Given this list of marker genes NAMPT, ZFHX3, MYBBP1A, LGR4, KDM8, NOCT, PASD1 (PAS domain containing repressor 1), RORC, PPARGC1A, RELB, TOP1, DRD2, ATF4, SIRT6, OGT, CRY1, MYCBP2, ZPBP2, PER1, ID2, KDM2A, HDAC1, MAGED1, PER3, HUWE1, KDM5A, RBM4B, PER2, RBM4, HDAC2 (NCBI Gene Id 3066), USP2, PRMT5 (NCBI Gene Id 415048), CARTPT, BHLHE41, MTA1, SIRT1, RORA, CAVIN3, CRY2, PPP1CA, CIART (circadian associated repressor of transcription), NR1D1, HNRNPU, RAI1, AHR, MC3R, KMT2A, EGR1, CSNK1D, CLOCK, NPAS2 (NCBI Gene Id 84195), BHLHE40, BMAL2, NCOA2, GFPT1, NGFR, NUDT12, HDAC3, CSNK1E, BMAL1, PPP1CB, DRD3, NRIP1, PPARA, PPP1CC (protein phosphatase 1 catalytic subunit gamma), NR0B2, PML, here is a description of the gene set: studied in species Homo sapiens Any process that modulates the frequency, rate or extent of gene expression such that an expression pattern recurs with a regularity of approximately 24 hours. Human Gene Set: GOBP_CIRCADIAN_REGULATION_OF_GENE_EXPRESSION